The following is a description of a gene set: studied in species Homo sapiens The activation signaling of transcription factor nuclear factor-kB (NF-kB) plays central role for immune system. One of key kinase mediating this pathway is TAK1 in adaptive and innate immunity. However, role of TAK1 in B cell receptor signaling is still unclear. To know effects of TAK1-deletion on the gene expression induced by anti-IgM, we performed the time course analysis in comparison of wild type with TAK1-deleted splenic B cells. Genes down-regulated in B lymphocytes: untreated versus anti-IgM for 3h. from publication Shinohara H, Behar M, Inoue K, Hiroshima M, Yasuda T, Nagashima T, Kimura S, Sanjo H, Maeda S, Yumoto N, Ki S, Akira S, Sako Y, Hoffmann A, Kurosaki T, Okada-Hatakeyama M (PMID 24833394) Human Gene Set: GSE41176_UNSTIM_VS_ANTI_IGM_STIM_BCELL_3H_DN, and this is the list of marker genes: MYCL, TIMM9, IRAG2 (NCBI Gene Id 650574), ZNF516, DCXR, USP20, ERCC5, LDLRAP1 (NCBI Gene Id 81862), SH3BGRL, TTC13, RITA1, ZNF331, DUSP7, CEP63 (centrosomal protein 63), EIF4EBP1, CTNNBIP1, MYH2, CDKN1C, BTK, PAGR1, ASTE1 (asteroid homolog 1), GUSBP14, RREB1, PDK4, ECI2, PARP8, CZIB, PRPF19, ITGAE, ARHGEF3, NINL, CPNE3, DMXL1, KAT2B, SESN1, GPATCH1, PPP1CC, SNRPC, ARMH3, NOL8, MACF1, IFIT2, CMTR1, PPOX, CAMK2G, MIS18BP1, EVI2B, CTSS, MICAL1, XPC, C11orf21, DNAJC13, NARS2, MRPS18B, POLB, DHRS9, ZNF623, NOCT, MPC1, GTPBP6, MAN2A2, CKAP2, UFC1, MNDA, IFT20, ARL6IP5, DCAF8, SLC22A5, OXA1L, ZNF574, LIMD1, FBXL4, PRKX, NPRL2, ORAI3, NEK9, KIF22, CD52, CEP68, LCMT1, ZNF34, SPIDR, HLTF, CCS, CNPY3, IFI16, ANKFY1, SIDT2, CENPE, WWP1, OCEL1, CEBPA (NCBI Gene Id 1050), STMN1, KIAA0586, IFIT1, KLHL24, RUSF1, VPS11, ADCY7, TLR5, OAS1, KIAA0513, PTPN22, PRKRIP1, PWP2, FBXO41, PPIH, MANEA, SNUPN, TRIT1, CALM2, CD1D, GMPR2, AVPI1, SDHAF1, PLCG2, IPCEF1, MSH2, H1-3, SMC2, IFFO1, INPP4A, SLC35A1, ASRGL1, NFATC3, NAIP, PMS1, SLC23A2, HHEX, ARHGEF18, DOP1A, OTULINL, COX4I1, CD9, ENOX2, SLC50A1, TEX2, INSR, SUOX (sulfite oxidase), IMP3, EPRS1, NUBPL, EIF2B1, ALDH2, ZDHHC7, CXADR, ARHGAP44, EEA1, USP48, C2CD2L, ATP5MC2 (NCBI Gene Id 517), TPCN1, FAM13A, TTC38, ARL4C, APOBEC3A, ZNF75D, RHOT1, POLI (NCBI Gene Id 11201), PRSS23, EPHB2, OXR1, PTPN4, AAAS, BAIAP2, EPS8, RNF113A, PNPLA4, H4C11 (NCBI Gene Id 8363), SSBP2, AFF1, CDH13, ADORA3, ZNF16, SCARB2, SREK1IP1, CELF2, RGS2, RANBP6, RPP38 (ribonuclease P/MRP subunit p38), H4C2, GFOD1, MAP3K3, ARHGAP45, CALHM2, FYB1, EIF3L, APEX1, NCL, VSIG4, MBNL2, MLYCD, USPL1 (ubiquitin specific peptidase like 1), PITX2, RNF141, ABHD10, MRTFB